Given this list of marker genes Cand1, Trp53, Creb1, Ikzf1, Ahr, Wnt10b, Psmc6, here is a description of the gene set: species: Mus musculus Any process that activates or increases the frequency, rate or extent of RNA polymerase II transcriptional preinitiation complex assembly. Mouse Gene Set: GOBP_POSITIVE_REGULATION_OF_RNA_POLYMERASE_II_TRANSCRIPTION_PREINITIATION_COMPLEX_ASSEMBLY